The following is a description of a gene set: Sorted B cells using flow cytometry. CD19 selected B cells were sorted using flow cytometry. from publication Longo NS, Lugar PL, Yavuz S, Zhang W, Krijger PH, Russ DE, Jima DD, Dave SS, Grammer AC, Lipsky PE (PMID 19023113) studied in species Homo sapiens Genes down-regulated in comparison of germinal center B cells versus plasma cells. Human Gene Set: GSE12366_GC_BCELL_VS_PLASMA_CELL_DN, and this is the list of marker genes: SELENOM, AQP6, ATRN, CPNE5, MIA3, LGALSL, SLC35B1, ISCU, KLK1, COPB2, FOXO3, TM9SF2, DNAJC3, SPON2, ERO1B, ST6GALNAC4, INPP4A, FUZ, TPP2, CUTA, UBA5, CELF3, VEGFA, PSME1, MST1, MBD1, SIRT2, WDR45, LRPAP1, FUT7, LINC00899 (NCBI Gene Id 100271722), CNTFR, OSBPL3, SRP68, AAMP, PRX, ACOXL, CCPG1 (NCBI Gene Id 9236), OSBP, AHNAK (AHNAK nucleoprotein), SEC11C, TMEM39A, DENND6B, SGK3 (NCBI Gene Id 23678), RASSF6, TMEM132A, SPCS1, CYP11B2, CHST15, WT1-AS, SRPK3, H2BC6, TP53INP1, MTMR9LP, WSCD1, SLC1A5, MGLL, GORASP2, CASP1, PI16, S1PR4, CD38, PRRC1, PIGK, EDEM3, IGLV4-3, ZRANB2, TPBGL, FBXL16, LINC02874, RGS2, FKBP7, EIF4E3, HOXB7, SOCS3, PDE3B, LINC03011, CD55, PAOX, C20orf202, ZNF653, ZNF574, ABHD12, ARFGAP3, IL34, MAFB, ROBO3, YIF1A, PRXL2C, MAST1, CFAP54 (NCBI Gene Id 651681), SRPRB, BTN3A2, CDH19, IER3IP1, CREBL2 (cAMP responsive element binding protein like 2), SLC39A7, CHPF, QPCT, GPHA2, GARIN5A, C2orf92, EIF2AK3, TM9SF1, COL13A1, TMEM184B, MANEA, SPTBN1, SCARB2, CCRL2, FTSJ1, AP3D1, TNFRSF17, SHANK1, MTDH, LIMD1, HDLBP, CCNC, HOXB4, MGAT1, KLHDC2, PTPN23, NFXL1, BTG2, CNPY2, STAT1, ATAD3B, AARS1, BBOF1, HSPG2, ACVR2A, CDNF, STK4, FAM114A1, TMED7, AMIGO3, C4BPB, GRAMD2A, PAPSS1, UCN3, DNAH2, ELL2 (elongation factor for RNA polymerase II 2), RDX, AMACR, PTGER2, WWOX, PKD1P1, NETO2, TMEM115, ENKD1, TARS3, ANKRD11, PARP4, ALG3, KIF1C, IRF7, MRNIP, DIRAS1, SEC24A, CARINH, CCDC14, PDX1, EXD2, TSPYL2, EFEMP2, APOL1, MXI1, CRYM, BTN3A1, ST6GAL1, RNF113A, MORF4L2, DAPK2, GPAA1, PRSS47P, ANKRD36BP2, TMED9, LINC01569, ERN1, BCL9, MAGT1, PRDX4, SEZ6L2, TAB1, ACE, ITM2C, HTR4, ITFG2, TNFRSF4, LYG1, ABCA3, STIMATE, CFLAR, SMPDL3B